The following is a description of a gene set: Genes predicted to be targets of miRBase v22 microRNA hsa-miR-1908-5p in miRDB v6.0 with MirTarget v4 prediction scores > 80 (high confidence targets). species: Homo sapiens Human Gene Set: MIR1908_5P from publication Chen Y, Wang X (PMID 31504780), and this is the list of marker genes: ACSL3, TNFRSF8, MDGA1, HOXC10, ESPN, DPP9, ABO, MIA2, NFIX, TGFB1, STPG1, SCRT1, DUOXA2, FKBP8, AP5Z1, SLC29A3